Given this list of marker genes PI16, TOMM70, MIR208A (NCBI Gene Id 406990), MIR199A1, IGF1, MIR199B, PAK1, GSK3A, AKAP6, COL14A1, PPARA, FOXP1, MIR19B1, RGS2, PARP2, YY1, EDN1, G6PD, MIR19A, CTDP1, CAV3, RGS4, here is a description of the gene set: species: Homo sapiens Any process that modulates the rate, frequency, or extent of the growth of a cardiac muscle cell, where growth contributes to the progression of the cell over time from its initial formation to its mature state. Human Gene Set: GOBP_REGULATION_OF_CELL_GROWTH_INVOLVED_IN_CARDIAC_MUSCLE_CELL_DEVELOPMENT